The following is a description of a gene set: species: Homo sapiens Any process that activates or increases the frequency, rate, or extent of interleukin-4 production. Human Gene Set: GOBP_POSITIVE_REGULATION_OF_INTERLEUKIN_4_PRODUCTION, and this is the list of marker genes: IRF4, HLA-E, IL33, PRKCQ, CEBPB, CD3E, SASH3, CD40LG, FCER1G, IL20RB, SYK, HAVCR2, RARA, CLECL1P, PRKCZ, EPX, CD28, LGALS9, IL1RAP, CD86, GATA3, TNFSF4, FOXP3, ZP3, PRG2, SLC7A5, NLRP3